Given this list of marker genes Fbxw11, Spry2, Zw10, Dynlt1b, Numa1, Ubxn2b, Fgf10, Pax6, Misp, Sapcd2, Plk1, Nsfl1c, Spdl1, Enkd1, Gja1, Ankfn1, Dctn1, Cenpa, Cdk5rap2 (CDK5 regulatory subunit associated protein 2), Mapre1, Spry1, Inppl1, Arhgef2, Kpnb1, Gpsm2, Gpsm1, Pkhd1 (polycystic kidney and hepatic disease 1), Pafah1b1, Bccip, Mcph1 (microcephaly, primary autosomal recessive 1), Ndel1, Kat5, Clasp2, Ndc80, Itgb1, Ccdc66, Nde1, Htt, Nusap1, Mad2l1 (NCBI Gene Id 56150), Clasp1, Hdac3, here is a description of the gene set: species: Mus musculus The cell cycle process in which the directed movement of the mitotic spindle to a specific location in the cell occurs. Mouse Gene Set: GOBP_ESTABLISHMENT_OF_MITOTIC_SPINDLE_LOCALIZATION